Given this list of marker genes ZFX, FH, PHGDH, EXOC8, IFT43, ZBTB18, FOXF1, NEDD4L, SETBP1 (SET binding protein 1), NPHP3, ZSWIM6, here is a description of the gene set: A cyst occurring within the choroid plexus within a cerebral ventricle. Human Gene Set: HP_CHOROID_PLEXUS_CYST Choroid plexus cyst studied in species Homo sapiens